Given this list of marker genes Avpr1b, Ang, Agtr1b, Ang5, Ang6 (NCBI Gene Id 630952), Rhoa, Ccl5, Apoa5, Nr1h2, Ang4, Plaa, Apoa4, Arhgap6, Ang2, Apoh (apolipoprotein H), Ccn1 (cellular communication network factor 1), Agtr1a, Lmf1, Pnlip, Rhoc, Gpihbp1, Plin5, Apoc2l, Fgfr2, Fgfr3, Pla2g5, Apoc2, Nr1h3, here is a description of the gene set: studied in species Mus musculus Any process that increases the frequency, rate or extent of lipase activity, the hydrolysis of a lipid or phospholipid. Mouse Gene Set: GOBP_POSITIVE_REGULATION_OF_LIPASE_ACTIVITY